Given this list of marker genes FLVCR1, SLC44A5, SLC5A7, SLC44A1 (solute carrier family 44 member 1), SLC44A2, SLC44A4, SLC22A2, FLVCR2 (NCBI Gene Id 55640), SLC44A3, here is a description of the gene set: Enables the transfer of choline from one side of a membrane to the other. Choline (2-hydroxyethyltrimethylammonium) is an amino alcohol that occurs widely in living organisms as a constituent of certain types of phospholipids and in the neurotransmitter acetylcholine. Human Gene Set: GOMF_CHOLINE_TRANSMEMBRANE_TRANSPORTER_ACTIVITY species: Homo sapiens